Given this list of marker genes SLC2A3, SLC4A4, LDHA, CA4, SLC16A3, CA2, SLC1A2, NUDT14, SLC16A1, HK1, SLC16A7, SLC2A1, LDHB, here is a description of the gene set: species: Homo sapiens Lactate shuttle in glial cells Human Gene Set: WP_LACTATE_SHUTTLE_IN_GLIAL_CELLS